The following is a description of a gene set: Abnormal neutrophil morphology Human Gene Set: HP_ABNORMAL_NEUTROPHIL_MORPHOLOGY An abnormal form or size of neutrophils. studied in species Homo sapiens, and this is the list of marker genes: CUBN, AMN, CXCR4, SFXN4, LBR, SMARCD2, TMEM147, TET2, CEBPE, MPO, NBAS, MTHFD1, FTCD, LYST, MYH9, SLC19A1, RPS14, SF3B1